The following is a description of a gene set: Up-regulated genes in the 'Field Effect' signature of normal lung tissue adjacent to the tumor. from publication Stearman RS, Dwyer-Nield L, Grady MC, Malkinson AM, Geraci MW (PMID 18172294) species: Mus musculus One area of intensive investigation is to understand complex cellular and signaling interactions in the tumor microenvironment. Using a novel, although straightforward, microarray approach, we defined a gene expression signature from the lung tumor microenvironment in the murine A/J-urethane model of human lung adenocarcinoma. The tumor microenvironment is reflected by the composition of the cell types present and alterations in mRNA levels, resulting in a Field Effect around the tumor. The genes composing the Field Effect expression signature include proteases and their inhibitors, inflammation markers, and immune signaling molecules. By several criteria, the Field Effect expression signature can be attributed to the macrophage lineage, suggesting a qualitative change in the expression pattern of tumor-associated macrophages (TAM) observed in lung tumors. The protein expression levels for a number of Field Effect genes were verified by Western blot analysis of lung homogenates, and for their expression in macrophages and parenchymal cells outside of the tumors by immunohistochemistry. In addition, the Field Effect expression signature was used to classify bronchoalveolar lavage (BAL) cells from tumor-bearing or age-matched control mice. Using a variety of statistical measures, the Field Effect expression signature correctly classified the BAL cells >94% of the time. Finally, the protein levels for several Field Effect genes were higher in cell-free BAL fluid, indicating they may be secreted by the TAMs. This work suggests that TAMs generate a unique gene expression signature within the tumor microenvironment, and this signature could potentially be used for identifying lung cancer from BAL cells and/or fluid. Human Gene Set: STEARMAN_TUMOR_FIELD_EFFECT_UP, and this is the list of marker genes: CCL23, MPEG1, LPL, LILRA4, CD200, MYO7A, ITIH4, F7, ACP5, CLEC4A, LY75, LRG1, CTSK, CTSS, ITGAX (NCBI Gene Id 3687), SOCS3, SAT1, CTSZ, CTSD, WFDC21P, SERPINA10, CCN3, CSTB, SCD, WDR81, CD68, LCN2, PTGS1, SCARB2, PLD3, IQGAP1, SPP1, LYZ, PLET1, APOC1, CSF2RB, CHI3L1, SIRPA